Given this list of marker genes AGT, DRD2, STC1, NPPB, SPX, NHERF1, EDN1, CORIN, AGTR1, NPSR1, NPR1, here is a description of the gene set: studied in species Homo sapiens Human Gene Set: GOBP_REGULATION_OF_EXCRETION Any process that modulates the frequency, rate, or extent of excretion, the elimination by an organism of the waste products that arise as a result of metabolic activity.